The following is a description of a gene set: Binding to an RNA polymerase core enzyme, containing a specific subunit composition defined as the core enzyme. Mouse Gene Set: GOMF_RNA_POLYMERASE_CORE_ENZYME_BINDING species: Mus musculus, and this is the list of marker genes: Smyd3, Rrn3, Supt4a, Ago2, Recql5, Hnrnpu, Rtf1, Dhx9, Paf1, Maf1, Uri1, Rpap2, Esrrb, Polr2m, Spty2d1, Scaf8, Leo1, Erbb2 (erb-b2 receptor tyrosine kinase 2), Supt4b, Ncoa3, Pcf11, Brd4, Wac, Ercc5, Scaf1, Smyd2, Elp2, Rprd1a, Cdc73, Ago1, Myzap, Gtf2b, Rprd1b, Elof1 (NCBI Gene Id 66126), Rtraf, Ccar2, Zfp326, Scaf4 (NCBI Gene Id 436384), Uvssa, Ctr9, Pcif1, Rprd2, Wdr43, Elp4